The following is a description of a gene set: Human Gene Set: GOBP_REGULATION_OF_GLUCOCORTICOID_METABOLIC_PROCESS studied in species Homo sapiens Any process that modulates the frequency, rate or extent of the chemical reactions and pathways involving glucocorticoids., and this is the list of marker genes: H6PD, STUB1, BMP5, GAL, BMP2, ATP1A1, NR5A2, WNT4, NR3C1, DGKQ, REST (NCBI Gene Id 5978), DKK3